Given this list of marker genes TFAP2B, UBE2J2, MRO, ASNS (NCBI Gene Id 440), PAX7, PA2G4, TMX1, PROM1, MDC1, PROSER1, PAWR, AURKA, PCGF5, XG, TEX30, ZNF232, KNSTRN (NCBI Gene Id 90417), ZNF107, ITGB2-AS1, CKAP5, MCM4, KIF23, CDC25C, C19orf48P, CCNC, PRR11, C4orf46, RIDA, LIG1, RAD1, WDR5, AKNA, MYBBP1A, RAB28, NUDT5, XPO4, NECTIN3, SMAD4, SKA2, PCK2, GALK2, LRR1, ERI1, PRKCB, MITD1, CARNMT1, SEPTIN10, COLGALT2, PAX6 (NCBI Gene Id 5080), TRA2B (NCBI Gene Id 6434), EXOSC3, RNF138 (NCBI Gene Id 51444), DDX3X, MED8, LPAR1, MKRN2, ZHX1, PSMC3IP, LINC01128, RALGPS2, RTN4IP1, TUBG1, EXOSC2, SS18, STUM, HNRNPAB, PRKAA1, ABCB10, FAS, OTUD6B, SLC37A4, EIF5B, KIF18B, BRCA2, SLC43A3, STAU2, CAV1, MELK, TMEM237, CES1, VEGFA, PTP4A1, ARHGAP17, CNOT9, PRAMEF1, ETS2, CENPM, KIF20B, SERP1, PSMG1, MSANTD3, DAB1, TOP2A, PLXDC2, PRDX3, IPO7, DIMT1, PPFIA1, LIN52, SLBP, H4C12, ANP32E, DLEU2, RLIG1, NAP1L4, SSX2, CSTF1, SDHAF3, RRP1B, CUX1, HSPA9, MRTO4, SRRM1, KCTD9, ALYREF (Aly/REF export factor), CCNB1, ATP23 (NCBI Gene Id 91419), ARL6IP6, TBCE, NEMP1, METAP2, BAG2, UHRF1, LINC00339, DDHD1, TMEM107, TCF19, JPH1, PKMYT1, PGD (phosphogluconate dehydrogenase), ERCC4, COPS5, C1orf43, CLN6, CDCA7, CCNJ, DEK, RAB23, PBRM1 (polybromo 1), FAM161A, CTPS1, PER2, BCCIP, WDSUB1, NEK2, TEAD4, ME1, MAT2A, LRRCC1, CENPF, FBXO5, MTFR1, RFC5, SSH1, ASF1A (NCBI Gene Id 25842), GINS2, SPC25, HSF2 (NCBI Gene Id 3298), CASP8AP2, EXOC5, HSPA8, TRIB3, CCDC86, MRM2, FEN1, BMP2, PLP2, MPDU1, ITGB3BP, C11orf58, SLC38A5, NPY1R, HMGB2, GTF2A1, NUDT12, EXO1, PPARGC1B, TRMT61B, DIDO1, ATL2, OSBPL3, OMA1, PALS1, EFCAB7, FAM111A, SSRP1, CDCA8, SLC1A3, GTSE1, UBE2V2 (NCBI Gene Id 7336), PAK2, ZNF567, ORC6, NUDT21, SYCP1, KCNK3, EPOR, UAP1, BUB1B, RFC2, CCDC138, PEX2, MRPL19, NBPF3, PXN, TAF2, GSTM1, POLR3C, SRP54, RPA1, AMPD1, NBPF9, NUP85, ZNF367, ARL4C, ACSL4, PMAIP1, SLC3A2, PUS1, CDR2, FASTKD3, NIPA1, SNRNP40, PRIM1, NOP56, ZNF93, DCDC2, SLC35A3, PPP2R5E, MN1, GTF2H2, NUP58, FARSB, GATA3, SENP3, MCM2, FAM199X, NEK4, BUB1, USP6NL, PSMD11, CYRIB, UCHL5, KNL1, DARS2, LARP1B, ESD, AGAP1, GABPB1, SNW1, SQLE, CTH (cystathionine gamma-lyase), POGK, EIF1AX (eukaryotic translation initiation factor 1A X-linked), UCK2, PSMD13, CHORDC1, TRNP1, USP31, SRPK2, ME2, LMO4, SMC4, RMI2, PLEKHF2, SORD, SUV39H1 (SUV39H1 histone lysine methyltransferase), SAFB, KIF13B, AUNIP, PPID, ELOC, GINS3, CLDN1, TAMM41 (TAM41 mitochondrial translocator assembly and maintenance homolog), GPD2, LIPT2-AS1, PSAT1, TRPC4, MCM10, SNRPD1, ASPM, XPO7, NMB, TRMU (tRNA mitochondrial 2-thiouridylase), SUCLA2, METTL8, KMO, COQ9, DBNDD1, NOM1, GEMIN4, VWA5A, TMPO, TMSB15A, PARP11, CENPJ, HMMR, HNRNPC, PAQR3, CDK9, NIFK, VKORC1L1, GDAP1, RTCA, TACC3, SMN1, PRPF40A, ZNF138, FANCG, FCGRT, SRGAP2, GYG2, PTPN5, SLC5A6, RAD51, PSMD10, PSMD1, CUL1, PTTG3P, NUP62, CDC20, SEMA5B, ATAD2, MKI67, PGRMC1, OTX2-AS1, KIF5B, SYN1, TM9SF3, IMPA2, NUP155, ZNF354C, RNF115, RBBP5, CDC25A, ILF3, MED17, FOXRED2, PISD, CEBPB, GLRX3, HS2ST1, DHX15, N4BP2, DUS4L, PPA2, CDS1, CAPZA2, NSG2, PKP4, TTK, ENOPH1, XPNPEP1, MCM7, RPP25, BNIP1, MED6, PHF20L1, PRMT6, UQCRC2, STEAP1, PTBP1, USP47, PHF5A, RTTN, RAD23A, PI4K2B, IFRD1, ATAD3A, PNO1, DNAJC9, UBE2G1, MYO19, NUCKS1, SLAIN1, HIGD1A, DNAJB6, MBD4, NUDCD2, TUBB2A, CHAF1B, ALKBH2, RAB1A, ABHD3, HYLS1, RHEB, RNF126, TKT, NUP205, CSNK2A1, ATF7, RANBP9, ZNF746, BRI3BP, GLOD4, ENO1, CCDC117, PINX1, RRM1 (ribonucleotide reductase catalytic subunit M1), TIMELESS, EAF2, PPIF, SH3GL3, ATAD5, ZNF398, CEP152, CDCA5, PGLYRP2, CUL3, DPF3, FAM220A, NFYA, MTHFD1 (NCBI Gene Id 4522), HTATSF1, DKC1, CEP85, DUSP26, PARD6B, LINC02762, CRLF3 (NCBI Gene Id 51379), SUGT1, HNRNPF, INSYN2B, AKR1B10, NCBP1, SSX2IP, RAP1GAP, TACC1, BORCS5, CHEK1 (checkpoint kinase 1), METTL21A, SPOPL, RBM14, RSPRY1, DNA2, BOP1, UQCC3, POU3F2, CNIH4, DCTPP1, LONRF1, UTP4, EIF5A, TPX2, GMCL1, MSH2, RFC4, RFWD3 (ring finger and WD repeat domain 3), CSTF3, MTMR4, MAD2L1, TCEA1, KIF11, CENPA, ZW10 (zw10 kinetochore protein), SLC24A3, ENTPD3, GNL2, NCAPH, TEDC2, AURKB, LARS1, APIP, PAICS, GTF2A2, CYCS, ACTB, SINHCAF, SLC1A5, NAA50, OBI1 (NCBI Gene Id 86572), SLC20A1, DDIAS, ACTR2, H4C3, POLQ, ANKRD46, CWF19L2, ISG20L2, FBXO22, SLC25A14, WDHD1, UBE3D, CCDC34 (coiled-coil domain containing 34), PRC1, NSFL1C, RMI1, DTL, FIRRM, CCNB2, SLC16A1-AS1, SKP2, ALG6, SKA1, RAB3IP, GOT1, TIMM29, RFC3, FDX1, PTGER3, POC1B, RAD18, PPP1R16B, HOXD13, MCM3, NUDT4, CEP78, MCM5, PPP5C (protein phosphatase 5 catalytic subunit), UBE2S, TMEM97, PRIMPOL, ZNF680, DDX54, BCL6, DYNC1I1, FOXM1, KLHL23, MYB, IMMP1L, LIAS, CLSTN2 (calsyntenin 2), RRM2, UBR7, TUBB6, CPSF2, PLRG1, CRYGS, SLC25A21, NUF2, ZNF207, ABHD17C, SPRED2, GFM2, NEDD4, SNRPF, TUBGCP4, ZNF639, DARS1, EIF2S2, NCAPD2, KIF2A, GRM2, PRUNE1, PLAA, HNRNPR, E2F5, STIP1, FJX1, DTYMK, JCAD, ATF1, NRAS, FAM72C, TMTC3, G3BP1, BAG5, TEAD2, UBE2T (ubiquitin conjugating enzyme E2 T), DUS2, COMMD10, SNRPA1, SENP6 (SUMO specific peptidase 6), FLI1, NADK, DONSON, CYB5A, BPHL, CEP55, PTPN11, MCMBP, ATR, JPT2, TNFSF13B, TTC33, POC5, RNF175, CMAS, PPA1, HSP90AA1, DHX33, PKP1, MASTL, NUP88, PPP6C, RBM12, AMMECR1, INCENP, SCNN1G, MIEF1, G2E3, DLGAP5, AATF, TIMP3 (TIMP metallopeptidase inhibitor 3), CDKN3, PAQR4, MAT2B, KPNA1, HSP90AB1, FRMD5, E2F6, AKAP12, NOL12, KDSR, RNASEH2A, PKP2, RAPH1, FGF13 (NCBI Gene Id 730528), HMGB3P1, CLGN, PIAS2, ARF1, ALG13, SLC9A3, USP39, PECR, DCK, SLC25A33, SNRNP27, ADRB3, KIAA1143, POLR3F, SNRPA, C1QBP, PATL1, RAD54B, SNRNP48, UGT3A1, RPE, DYRK3, MAPKAP1, MAFB, ZNF512, GRPEL1, MAP7D2, PI15, TYMS (NCBI Gene Id 7298), KIF14, GEMIN2, ANLN, FANCD2, WBP11, MAP2K2, HMGB1 (NCBI Gene Id 3146), TEFM, C9orf72, AIRIM, HSPD1, EIF3M, PAQR5 (NCBI Gene Id 54852), CDC45, MRPL39, KIF18A, ACOT7, LARP4, SLC16A1, PTBP3, NR0B1, METTL4, CBR3, FADS3, FEM1B, HSD17B2, CRYZ, KLHL13, NARS2, ORC1, CHEK2, MEMO1 (mediator of cell motility 1), TFDP1, TSEN2, PRPS2, EXO5, CDK2, CNOT1, ARIH2, CENPS, TMPO-AS1, PIMREG, PANK3, SFPQ, FSBP, ESPL1, DAAM2 (NCBI Gene Id 23500), NR2F2, GRK5, FUS, ZNF850, NUP50, TTF1, SNAPIN, MFF, BLTP3A, ASRGL1, SGK3, PWWP3B, TSEN15, FBXO28, DBR1, KCTD3, STX18, APBB2, SNAPC5, EARS2, BRIP1, RACGAP1, PARP1, LBH, ZIK1, GPALPP1, MCM6, NUP35, ARPC2, EPB41, CALM1, PPP2R5D, CYB5R4, MTFMT (NCBI Gene Id 123263), SIPA1L1, LDB2, SOX2, ICMT, AASDHPPT, ACLY, ADSS2, HNRNPU, EIF2B1, SPDL1, ECT2, NANP, USP45, OIP5, CAV2, TSN, DPYSL5, EMC6, RAP1A, MAPRE1, C9orf40, CBS, NSD3, GCH1 (GTP cyclohydrolase 1), PARPBP, TMEM19, USP10, AMZ2, GTF2F2, EIF4EBP1, RUBCNL, SLC35F3 (solute carrier family 35 member F3), MAP3K7, CEP135, PDS5A, NLGN4X, AIMP1, NTAQ1, TSR1, LEF1, THUMPD3 (THUMP domain containing 3), IDO1, ERCC6L, FIGNL1, LRP8, KNTC1, RADX, NXT2, RHNO1, NANOS1, FANCI, RCOR1, CCDC43, YWHAE, HJURP, CACNB2, XRCC5, ANKRD9, EIF2A, C1orf226, ZNF681, AP5M1, CYB5B, CA13, PIGX (NCBI Gene Id 54965), HNRNPA3, NMT1 (N-myristoyltransferase 1), SEPHS1, ARPC5, CENPH, PCBP1, OGFRL1, WWOX, DNAAF5, C2orf69, PRPF4 (pre-mRNA splicing tri-snRNP complex factor PRPF4, NCBI Gene Id 9128), NONO, GMNN, RAD51AP1 (NCBI Gene Id 10635), DHFR, PPP2R2A, UBE2G2, IL1RAP, NEIL3, DDB2, DEPDC1B, LUC7L, GFPT1, NFATC3, SYNPR, TUBE1, FBXO43, XPO5, NETO2, CDC6, DCUN1D1, HAUS4, YEATS4, LOXHD1, BLMH, KCNE3, BLM, MBD3L2, CTSC, TRHDE, SUDS3, LYPD1, EDEM3, HMGB3, MRPL15, IDH3A, HAUS1, SEC11C, CDKAL1, MGME1, CENPO, NUP153, MYBL2, IFI44, SMC6, GORASP2, SIRPAP1, DPH3, ANKRD13C, TOMM22, ERO1A, PLS1, SRP72, PCNA, C16orf87, SMCO4, LSM10, EMP2, KIF4A, ADD2, SCMH1, E2F2, HMGN5, RCN3, ZNF280C, NCAPG, NDUFAF4, MCUR1 (mitochondrial calcium uniporter regulator 1), SF3A1, TMED5, SLCO4A1, CACYBP, PSME3, DNMT1, DDX39A, APPL1, PALS2, CNTNAP2, SOAT1, CENPN, BARD1, USP21, TRAF3, MEIOB, GLE1, CCT2, NUDCD1, YBX1, SLC29A1, SMARCC1, TRIP13, POLA2, APELA, DCP2 (NCBI Gene Id 167227), GDI2, RUVBL1, SIK3, SEH1L, UBE3A, ALKBH5, HK2, DHX8, PCLAF, MT1F, QRSL1 (glutaminyl-tRNA amidotransferase subunit QRSL1), PLSCR1, FAM91A1, STAG1, HOOK1 (NCBI Gene Id 51361), RANBP1, E2F8, NMI, DNAL1, MTDH, ATP2A2, FAR1, BRF2, PGK1, MPHOSPH9, MTMR6 (myotubularin related protein 6), NDFIP2, CDH12, DBNDD2, RIF1, TRMT6, NOC3L, CIAPIN1, IGF2BP1, NPM1, ZDHHC6, ANP32A, FH, BRCC3, FUBP1, CTDSPL2, STK32B, ABCF2, SPPL2A, NFYB, RNF182, CDCA4, ARHGAP19, EME1, RANGAP1 (Ran GTPase activating protein 1), RAD54L, XPNPEP3 (NCBI Gene Id 63929), GRSF1, CDC42SE2, CHAF1A, GDE1, NOL7, PPP1R2, AFG3L1P, SGO2, BRCA1, GEMIN5, CLOCK, PRIM2, GPAM, E2F1, CDT1, DIPK2A, PPP1R8, ROR1, FNIP2, POLR2D, NUP160, ZNRF3, POLA1, SLC1A4, PRR5L, ACP1, MYBL1, NRN1, RRS1, DEPDC1, XRN2, GRB10, DICER1, PPP1R7, NEXMIF, DBF4, SELENOT, SLC25A32, SLC35F2, CDK13, ATG5, TXLNG, TICRR, RAB14, IQGAP3, GINS4, MLX, VPS29, AEN, ZNF507, YRDC, APCDD1, GHITM, TMEM132B, PPAT, POLE2, MAB21L3, AHSG, DNAJB1, ASF1B, MAPK6, HACD3, POLE3, TCP1, ISM2, CENPV, NUSAP1, TRPM4, MAP2K1, UBQLN1, COL4A1 (collagen type IV alpha 1 chain), TOX2, ISOC1, HELLS, ZPR1, USP1, RFC1, MACROH2A2, MGAT4C, PPP2R1B, CRKL, TK1, MND1, PFKP, ZRANB3, LEMD2, HNRNPD, SLC19A1, MTHFD2, LMNB1, LSM4, POC1A, BRD7, SH2B3, CLEC11A, ANKH, HNRNPH1, VAMP3, TUBGCP3, GART, POLR2K, COPS3, SV2B, NIP7, MIB1 (MIB E3 ubiquitin protein ligase 1), CLCA1, ITPR3, THOP1, PPP2R2D, KICS2, ZNF496, CENPL, LIN9, RBBP4, TIMM21, YME1L1 (NCBI Gene Id 115724), AK2, DDX19B, HAUS8 (HAUS augmin like complex subunit 8), SMC3, SDHC, WDR76, SLFN11, NET1, HMGB1P4, BZW1, TMEM70 (NCBI Gene Id 54968), MRPL50, FAM120AOS (NCBI Gene Id 158293), SRD5A3, CCND2, DENND2C, TMED2, NUFIP1, LRRC4C, KCNA2, UBE2N, DLAT, GET1, GCFC2, TIPIN, RNF228, C6orf136, CPD, TAF5, PDS5B, MAGOH, GSTM4, CDC5L, ARMC1, NPM1P22, ORC2, NBN, HNRNPL, KIF2C, DNAJC12, NSD2, PTTG1, EMC9, HLTF, PRKD3, SRSF10, CDCA2, KCNQ5, POLD3, SAE1, DDX18, PUS7, KPNA2, KDELR2, MZT1, AGO2, PRPS1, ACYP1, MRPL48, ADH5, CRNDE, YWHAH, PRKDC, CCNE2, TMEM38B, UMPS, HNRNPDL, MRPL42, STEAP2, SLC30A5, NGFR, KIF15, RXYLT1, SKA3, PPP2R5C, GINS1, PNMA2, UBA2, CDK1, PTMAP3, UVRAG, NCKAP1L, CDC7, CHAMP1, TMEM245, USP37, HS6ST1 (NCBI Gene Id 9394), NTN4, FLRT2 (NCBI Gene Id 9822), SVIP, TMEM71, MATR3, MSH6, TTF2, LRFN5, RBM11, CDCA3, CYP4F22, SIRPA, KPNB1, BIRC5, PRR14, ZCCHC8, MYOM2, TNS1 (tensin 1), MRPS10, EXOSC9, GRIK2, ACKR3, SLC17A7, SET, RCC1, JADE1, UBR3, SLF1, OXCT1, SFRP2, PLAUR, PUDP, TREX2, TLK1, VAV1, UBR5, RBM27, SRSF3, GON7, ESRP1, TSEN54, SUV39H2, PACRGL, CCK, ZNF76, AMER2, UBR1, COA6, AKIRIN1, MTO1, DCLRE1B, PHLPP2, TPD52, NSUN4, ZWINT, RAD51C, RAC1, ETF1 (NCBI Gene Id 9190), FANCA, CRYZL1, SHMT1, PLK4, GEN1 (GEN1 Holliday junction 5' flap endonuclease), BCAS4, URI1, SRR, RPS2, HSPH1, JOSD1, THAP1, ASAP1, ZWILCH, MRPL30, NCAPG2, SPATA13, HAPLN1, USPL1, TPRKB, CDYL (NCBI Gene Id 9425), NDC1, C1orf21, SMYD4, ARG2, GGA2, RHOH, HADH, FAM162A, BRIX1, ORC5, E2F7, UMAD1, MAZ, ELAC2, TROAP, ITPK1, WDR4, WEE1, LAMB3, PLK1, NFYC, TAFA5, RPRD1A, TAF1A, MCM8, PPP1R1A, AARS1, GFM1, PABIR2, KRR1, FNTA, DDX21, WWP1, SRSF2, RAB8A, UBE4B, FAM83D, TRMT13, PTPRF, CMPK1, MIS12, MRPS15, POP1, EMC8, ETNK1, SLF2, ORMDL1, CCZ1, GPSM2, CDKN2AIP, PRKD1, SMC2, PASK, CCNF, NDC80, OTX2, GNB4, SRSF1, SERBP1, C18orf54, HAUS6, MATCAP2, BOLA1, PSMC3, CKAP2, ESF1, COIL, CKAP2L, here is a description of the gene set: Human Gene Set: KINSEY_TARGETS_OF_EWSR1_FLII_FUSION_UP Genes up-regulated in TC71 and EWS502 cells (Ewing's sarcoma) by EWSR1-FLI1 as inferred from RNAi knockdown of this fusion protein. studied in species Homo sapiens A number of solid tumors, such as alveolar rhabdomyosarcoma, synovial sarcoma, and myxoid liposarcoma, are associated with recurrent translocation events that encode fusion proteins. Ewing's sarcoma is a pediatric tumor that serves as a prototype for this tumor class. Ewing's sarcomas usually harbor the (11;22)(q24;q12) translocation. The t(11;22) encodes the EWS/FLI fusion oncoprotein. EWS/FLI functions as an aberrant transcription factor, but the key target genes that are involved in oncogenesis are largely unknown. Although some target genes have been defined, many of these have been identified in heterologous model systems with uncertain relevance to the human disease. To understand the function of EWS/FLI and its targets in a more clinically relevant system, we used retroviral-mediated RNAi to knock-down the fusion protein in patient-derived Ewing's sarcoma cell lines. By combining transcriptional profiling data from three of these lines, we identified a conserved transcriptional response to EWS/FLI. The gene that was most reproducibly up-regulated by EWS/FLI was NR0B1. NR0B1 is a developmentally important orphan nuclear receptor with no previously defined role in oncogenesis. We validated NR0B1 as an EWS/FLI-dysregulated gene and confirmed its expression in primary human tumor samples. Functional studies revealed that ongoing NR0B1 expression is required for the transformed phenotype of Ewing's sarcoma. These studies define a new role for NR0B1 in oncogenic transformation and emphasize the utility of analyzing the function of EWS/FLI in Ewing's sarcoma cells. from publication Kinsey M, Smith R, Lessnick SL (PMID 17114343)